Given this list of marker genes PFKFB1, PPP2CB, PPP2R5D, PPP2CA, PPP2R1A, PPP2R1B, MLXIPL, here is a description of the gene set: part of: Integration of energy metabolism Reactome Pathway: PP2A-mediated dephosphorylation of key metabolic factors species: Homo sapiens A member of the PP2A family of phosphatases dephosphorylates both cytosolic and nuclear forms of ChREBP (Carbohydrate Response Element Binding Protein). In the nucleus, dephosphorylated ChREBP complexes with MLX protein and binds to ChRE sequence elements in chromosomal DNA, activating transcription of genes involved in glycolysis and lipogenesis. The phosphatase is activated by Xylulose-5-phosphate, an intermediate of the pentose phosphate pathway. The rat enzyme has been purified to homogeneity and shown by partial amino acid sequence analysis to differ from previously described PP2A phosphatases - the human enzyme has not been characterized.